Given this list of marker genes Defa23, H2bc21, Defa38, Defb1, Defb40, Ltf, Defb10, Ear2 (NCBI Gene Id 13587), Defa20, Defa24, Defa39, Defa34, Rpl39, Il4, Defa41, AY761185, Defb11, Cldn2, Defb37, Defb2, Defb39, Defa31, Ear14, Defa2, Defa17, Defa22, Defa30, Defa21, Apoa4, Defa26, Camp, Defa25, Defa3, Defa37, Defa40, Ear6, Defa5, Ear1, Defa35, Defb38, Nod2, Defa42, Ear10, Defa29, Rnase2a, Defb9, Pla2g1b, Fau, H2bc12, Bpifb1, Rnase2b, Defa28, here is a description of the gene set: Any process of the innate immune response that takes place in the mucosal tissues. Mouse Gene Set: GOBP_INNATE_IMMUNE_RESPONSE_IN_MUCOSA species: Mus musculus